Given this list of marker genes E2F2, MAN1A1, ITGB8, GPR6, TGFBR2, LMO3, GRM5, BLCAP, PHKA1, PTPRD, ZNF385A, ARID5B, LRP8, PAK2, CMTR2, SS18L1, HECTD2, RNF6, ITGB4, MED12L, USP46, IRF2 (NCBI Gene Id 3660), ISM2, RORA, LCOR, SON, MBD2, SPRED1 (sprouty related EVH1 domain containing 1), GPM6A, IKZF2, ADAT2, TMTC2, NUFIP2, RABGAP1, RASGEF1A, VDR, CFL2, FSTL5, REEP3, BARX2, ARHGAP30, R3HDM1, CYBRD1, TIAM1, USP16, ARL4C, PIGA, SYDE1, CCNJ, AMER2, OXR1, NFIB (nuclear factor I B), ZNF827, QRSL1, SOWAHC, RASSF2, SYNC, UNC80, GPCPD1, GSTM3, ZRANB1, RTN1, SRCIN1, KAT2B, TIPARP, C6orf15, RFLNA, ANKRD45, TP53INP1, DCUN1D1, REST, SHC4, KPNA2, FRMD4A, UBE2J1, ITPRIPL2, RUNX2, PKD2 (NCBI Gene Id 5311), TBC1D2 (NCBI Gene Id 55357), LATS2, UBE2B, TMEM100, TNFAIP1, ZFYVE26, LEFTY2, RELA, GDF11, ARID4B, RBBP9, TWF1, USP24, RPS6KA3, ROCK2, C2orf69, ZCCHC24, PLAG1, GUCY1A1, ARHGEF17, TAPT1, PLAGL2, ANO6, MYRF, ADAM9, SLC15A2, CROT, HIF1AN, FNDC3A, ZBTB7A, TXNIP, PIGM, CXCL1, SLC22A23, MCL1, ZNRF3, CNOT6, YOD1, KIF3B, DDHD1, MARCHF11, RBL1, NFYA, PHACTR4, ZNF367, KDM1B, CUX1, RSF1, CREB5, LRP2, ZNF800, PKHD1, MYLK, SERF1A, JPT1, ANKRD17, DYNC1LI2, DPP8, SHCBP1, INHBB, MIXL1, SLAIN1, FAT4, CYP26B1, TRPS1, VLDLR, GNPDA2, SYTL4, LARP1B, CYBB, ELAVL2, CYB5D2, RAB11A, FZD6, INO80D, DUSP2, ZFX, RGMB, UBE2Q2, CREBRF, ZNF75A, RB1CC1, SUV39H1, MBNL3, NR4A3, CLIP4 (NCBI Gene Id 79745), HIPK3, KREMEN1, ERCC4, TNKS2, SMARCC2, E2F7 (NCBI Gene Id 144455), E2F5, FYCO1, PHF12, AAK1, RGL1, PAK5, PPP6C, ZNF532, FGD4, TANC1, DRD1, LYST, HAUS8, MSL1, ATF6B, ABHD3, HOOK3, EIF3M, MAPK9, DENND5B, SUCO, SUZ12, C2CD2, LHX8, ZNF362, GUCA1C, RAB5C, APP, ARID4A, TET1, TSHZ3, HP1BP3, GPR12, MPC1, DCUN1D4, ST7L, MTF1, MYCN, BTG1, RRAGD, PTPN21, GLCE, RAB11FIP5, SAMD12, SLC24A2, ASF1A, HS2ST1, NFIA, EDNRB, ALDH1L2, DNAJC27, ELK4, GLIS3, HDAC4, ARMC8, PPARA (peroxisome proliferator activated receptor alpha), KRTAP1-3, SSX2IP, TET3, ZKSCAN1, CAPRIN2, SKIDA1, TMEM64, CDCA7, ZC3H13, RSBN1, MAGEH1 (NCBI Gene Id 94692), PARP8, DNAI7, GALNT3, JAZF1, PAF1, AGO1, EZH1, GPC6, TCAIM, ARHGEF10, TRIM36, UNKL, ANKRD52, RYR2, TAGAP, PFKP, DCAF6, TET2, KIF26B, RELL1, RALGDS, RAB22A, RDX, PDE8A, IRF2BP2, MARCHF5, MKNK2 (NCBI Gene Id 2872), FGD5, ATAD2, NR2C2 (NCBI Gene Id 7182), TRAPPC14, ZNF77, TRIP11, CCSAP, SMNDC1, CDC23, HABP4, LAMA3, POLQ, TMEM170B, MIER3, ST3GAL1, CUX2, NPAS3, TMUB2, RAB11FIP1, TMEM86A, RFX3, MTUS1, FMR1, SPOP, FAM168B, CYP20A1, TSEN34, LRIT1, PSD3, TNRC18, DPYSL5, PHF14, PRRG1, CORO2B, LAMP5, PRDM8, SLC33A1, KMT5B, FZD3, OLFM3 (olfactomedin 3, NCBI Gene Id 118427), SLC16A10, BCL6, FAM219B (NCBI Gene Id 57184), SDC1, WDR37 (NCBI Gene Id 22884), EXOC5, CELF2, TBC1D8B, SLAIN2, MAP3K2, COG5, ASF1B, SLC16A6, MFAP5, MAP3K14, TMEM123, ZBTB11, EPHA5, SEMA3C, RAD18, BCL11A, SNX8, LHX6, ZNF260, H2AJ, MIGA2 (NCBI Gene Id 84895), SMIM14, ZBTB41 (zinc finger and BTB domain containing 41), SETBP1, SERF1B, ASAP1, ZBTB5 (NCBI Gene Id 9925), PDE4D, LEFTY1, SNRK, PRDM4, RNF216 (ring finger protein 216), PDIK1L, SLC40A1, PTGDR, SPTLC2, TFAP4, NHSL3, MCC, CPEB1, MIB1, MICA, ZBTB33 (zinc finger and BTB domain containing 33), RUBCN, here is a description of the gene set: Genes predicted to be targets of miRBase v22 microRNA hsa-miR-302a-3p, hsa-miR-302b-3p, hsa-miR-302c-3p, hsa-miR-302d-3p in miRDB v6.0 with MirTarget v4 prediction scores > 80 (high confidence targets). Human Gene Set: MIR302A_3P_MIR302B_3P_MIR302C_3P_MIR302D_3P from publication Chen Y, Wang X (PMID 31504780) species: Homo sapiens